The following is a description of a gene set: studied in species Mus musculus Mitochondrial biogenesis Mouse Gene Set: REACTOME_MITOCHONDRIAL_BIOGENESIS, and this is the list of marker genes: Atp5mc2, Sirt3, Atp5f1a, Atp5mg, Atp5me, Atp5po, Atp5f1d, Gabpb1, Atp5mk, Atp5pf, mt-Atp6, Atp5pd (ATP synthase peripheral stalk subunit d), Atp5f1e, Sirt5, Glud1, Dmac2l, Sod2, mt-Atp8, Atp5pb, Atp5mf, Atp5f1b, Sirt4, Atp5mc3, Gabpa, Atp5mj, Cycs, Acss2, Atp5mc1, Gm10053, Idh2, Atp5f1c